Given this list of marker genes RARB, HSF2, HSF1, SGO2, TEX15, RAD51C, TEX14, BSG, SPO11, MLH1, MEI1, PSMC3IP, SOHLH1 (NCBI Gene Id 402381), PMS2, DMRT1, SIAH1, SYCP1, MSH5, FKBP6, FUS, GNPAT, BMP8A, BCL2, H2AX, CCNA1, ATM, TEX11, EGR4, SYCP2, GAL3ST1, DAZAP1, IP6K1, UBB, BCL2L1, CKS2, MORC1, STX2, LIMK2, BCL6, CSTF2T, SYCP3, BRCA2, BTRC, DMC1, MLH3, PIWIL2, SLC25A4, H3-3A, PAFAH1B2, FANCA, UBE2B, BUB1B, CPEB1 (NCBI Gene Id 64506), TERT, REC8, HSPA2, BAG6, ERCC1, SMC1B, MSH4, MYBL1, EXO1, CDK2, LMNA, TRIP13, OVOL1, RARA, YBX3, CNOT7, UBR2, BCL2L2, PIWIL4, here is a description of the gene set: Reproduction is required for the survival of all mammalian species, and thousands of essential 'sex' genes are conserved through evolution. Basic research helps to define these genes and the mechanisms responsible for the development, function and regulation of the male and female reproductive systems. However, many infertile couples continue to be labeled with the diagnosis of idiopathic infertility or given descriptive diagnoses that do not provide a cause for their defect. For other individuals with a known etiology, effective cures are lacking, although their infertility is often bypassed with assisted reproductive technologies (ART), some accompanied by safety or ethical concerns. Certainly, progress in the field of reproduction has been realized in the twenty-first century with advances in the understanding of the regulation of fertility, with the production of over 400 mutant mouse models with a reproductive phenotype and with the promise of regenerative gonadal stem cells. Indeed, the past six years have witnessed a virtual explosion in the identification of gene mutations or polymorphisms that cause or are linked to human infertility. Translation of these findings to the clinic remains slow, however, as do new methods to diagnose and treat infertile couples. Additionally, new approaches to contraception remain elusive. Nevertheless, the basic and clinical advances in the understanding of the molecular controls of reproduction are impressive and will ultimately improve patient care. from publication Matzuk MM, Lamb DJ (PMID 18989307) Human Gene Set: MATZUK_SPERMATOCYTE Genes important for spermatocyte, based on mouse models with male reproductive defects. species: Mus musculus